The following is a description of a gene set: Human Gene Set: MIR6871_5P from publication Chen Y, Wang X (PMID 31504780) Genes predicted to be targets of miRBase v22 microRNA hsa-miR-6871-5p in miRDB v6.0 with MirTarget v4 prediction scores > 80 (high confidence targets). studied in species Homo sapiens, and this is the list of marker genes: ARHGAP24, ZFP82, BRPF1, HYCC1, PCDHA6, CD302, PURG, USP38, LY75-CD302, PCDHA13, ADAM22, PCDHAC1, PCDHA3, SCN3A, DDX3Y, CELF3, KLLN, AURKA (NCBI Gene Id 8465), PCDHA4, PCDHA7, C1orf74, PAK1, ARMC9, ALCAM, FUNDC1, PCDHA12, CHM, PGPEP1, ATL2, TIMM21, PCDHAC2, PCDHA11, COX20, FZD7, ELOVL4, TSPAN13, SLC8A1, GAS2L2, PCDHA10, PCDHA5, SEPTIN8, NDUFAF3, VEPH1, TNFAIP8L2, PCDHA9, BTBD18, PCDHA8, TRMT10B, FSTL4, NAV1, MYORG, IARS1, GNGT2, ACSL3, PCDHA2, GPR155, SLC22A16, UMAD1, PCDHA1